Given this list of marker genes AP2A1, CLTA, PRKCG, WNT5A, PRKCA, CLTC, FZD4, AP2A2, AP2B1, CLTB, AP2M1, DVL2, AP2S1, PRKCB, ARRB2, here is a description of the gene set: studied in species Homo sapiens Human Gene Set: REACTOME_WNT5A_DEPENDENT_INTERNALIZATION_OF_FZD4 WNT5A-dependent internalization of FZD4